The following is a description of a gene set: electronically inferred by orthology from the curated human pathway species: Mus musculus part of: Non-canonical inflammasome activation Reactome Pathway: CASP4-mediated substrate cleavage This event has been computationally inferred from an event that has been demonstrated in another species.<p>The inference is based on the homology mapping from PANTHER. Briefly, reactions for which all involved PhysicalEntities (in input, output and catalyst) have a mapped orthologue/paralogue (for complexes at least 75% of components must have a mapping) are inferred to the other species., and this is the list of marker genes: Casp4 (caspase 4, apoptosis-related cysteine peptidase), Casp3, Gsdmd